Given this list of marker genes RTP5, RTP3, RTP2, RTP4, REEP1, RTP1, here is a description of the gene set: Binding to an olfactory receptor. species: Homo sapiens Human Gene Set: GOMF_OLFACTORY_RECEPTOR_BINDING